Given this list of marker genes PIKFYVE, DDX3X, RHOBTB1, VEZF1, STARD7, SPTLC1, CTDSP1, MFSD2A, XPO6, AMER2, PAX5, NRP1, CLIC5, BEST3, PIK3C2B, ATOH8, RAPGEF3, KCNH5 (potassium voltage-gated channel subfamily H member 5), SRP9, ABHD14A-ACY1, NR2C1, SSUH2, USP15, HSCB, ATXN7, SEMA4D (NCBI Gene Id 349236), ABTB3, VPS37D, EGR3, SEPTIN11, PNMA3, KIAA1549L, ZBTB8A, SDC1, PRR9 (NCBI Gene Id 574414), ATP7A, TANC2, CALM1, CBLN2, CTDSP2, CERS2, CCDC117, TRAT1, INSL5, POGZ, NAB1, IRF2BPL, SLAMF9 (NCBI Gene Id 89886), MGA, MAPRE2, DCAF12, SYT9, SORCS1, ACY1, FAM20B, RALGDS, KIAA0232, AKT3, MYPN, PTHLH, ERN2, DLL1, VAT1, RSPRY1, DFFA, TMEM178B, CTBS, MACO1, DDX3Y, MARK3, TLE4, NPEPPS, TFB1M, SLC35D1, USP38, CNPY3, LDLRAD4, PAFAH1B2, ZNF316, PRDM10 (NCBI Gene Id 56980), GALNS, SUPT4H1, KCNQ3, ATF6, CNR1, FAM168B, MEX3C, UBE2R2, SMG1, ZNF518A, GNAZ, PHF20L1, TCEANC2, VCF2, LRRC10, ITPRID1, here is a description of the gene set: Genes predicted to be targets of miRBase v22 microRNA hsa-miR-212-5p in miRDB v6.0 with MirTarget v4 prediction scores > 80 (high confidence targets). species: Homo sapiens from publication Chen Y, Wang X (PMID 31504780) Human Gene Set: MIR212_5P